Given this list of marker genes Ap3d1, Ap1g1, Gli3, Rab27a, Kit, Bcl2 (B cell leukemia/lymphoma 2), Mlph, Gnaq, Cited1, Myo5a, Lrmda, Ednrb, Oca2, Gna11, Zeb2, Or51e2, Bloc1s3, Bloc1s6, Mreg, Sod2, Adamts9, Ankrd27, Ap1m1, Rab32, Sox10, Cd63, Kitl, Mitf, Mef2c, Rab38, Bloc1s5, Tyrp1, Adamtsl4, Edn3, Hps4, Hps1, Adamts20, Enpp1, here is a description of the gene set: Mouse Gene Set: GOBP_PIGMENT_CELL_DIFFERENTIATION species: Mus musculus The process in which a relatively unspecialized cell acquires the specialized features of a pigmented cell, such as a melanocyte.